Given this list of marker genes Pik3r2, Shc3, Irs2, Ret (ret proto-oncogene), Dok1, Nrtn, Gfra1, Dok5, Prkaca, Frs2, Prkacb, Gdnf, Grb2, Dok4, Pik3cb, Gab1, Prkca, Shank3, Artn, Shc1, Gfra2, Mapk7, Dok2, here is a description of the gene set: species: Mus musculus This event has been computationally inferred from an event that has been demonstrated in another species.<p>The inference is based on the homology mapping from PANTHER. Briefly, reactions for which all involved PhysicalEntities (in input, output and catalyst) have a mapped orthologue/paralogue (for complexes at least 75% of components must have a mapping) are inferred to the other species. electronically inferred by orthology from the curated human pathway part of: Axon guidance Reactome Pathway: RET signaling